Given this list of marker genes Ss18l1, Limd1, Parp6, Fyn (NCBI Gene Id 14360), Fn1, Myh14, Brwd1, Sema3e, Caprin2, Cul7, Cdc42se1, Cask, Palmd, Kit, Eef2k, Fblim1, Ccl11, Caprin1, Zranb1, Plxnb3, Vegfa, Slc30a1, Fbxw8, Rhou, Fmnl1, Arhgap15, Hdac6, Cux2, Stau2, Pakap, Sparc, Arhgdia, Mov10, Ccl24, Ankrd27, Gas7, Dapk3, Fermt2, Kif3a, Plxnb2, Cpne9, Xlr3b, Ezr, Smurf1, Reg1, Pak3, Bves (NCBI Gene Id 23828), Hck, Lpar1, Myo10, Nf2, Kalrn, Numb, Cdc42ep3, Enam, Rims1, Rhoj, Cdc42se2, Lst1, P2ry1, Rnf157, Fzd4, Septin7, Wtip, Ighm, Plekho1, Itga7, Cpne5, Syne3, Dvl2, Bcl9l, Mfn2, Ache, Mfn1, Syt4, Met, Myo9a, Crk, Zmym6, Rhobtb2, Strip1, Mfsd2a (NCBI Gene Id 76574), Tnik, Ptn, Coro1b, Coch (NCBI Gene Id 12810), Il6, Wdr1, Sema4d, Msn, Mecp2, Sh3glb1, Arhgef18, Ccl12 (NCBI Gene Id 20293), Arap1, Dlg1, Myl12b (NCBI Gene Id 98057), Fgr, Ptprd, Cdkl3, Fmnl3, Phip, Opa1, Ypel4 (NCBI Gene Id 241525), Dnm1l, Itpka, Fgd4, Fgd1, Cfap410, Macf1, Cldn4, Parvg, Shroom3, Map3k13, Camk2b, Syt17, Rreb1, Wnt5a, Reln, Cdc42ep4, Ccl7, Sprr2a1, Marcks, Cxcr4, Zmym4, Akap5, Arc, Epb41l2, Csf1r, Fbxo31, Prag1, Aldoa, Cyfip1, Atg16l1 (NCBI Gene Id 98282), Cacng7, Zmym3, Myh10 (myosin, heavy polypeptide 10, non-muscle), Kank1, Pten, Fitm2, Plxnd1, Pxn, Cpne6, Afdn, Syt1, Enpp2, Cldn3, Prkdc, Pias2, Dlc1, Tpm1, Gas2, Dmtn, Gna13, Lrp8, Ilk, Palm, Icam1, Coro1c, Obsl1, Plaa, Larp4, Picalm, Cfl1, Cd44, Src (NCBI Gene Id 99351), Kdr, Baiap2, Vil1, Arpin, S100a13, Cldn13, Epb41, Parva, Parvb, Myo5b, Cdkl5, Fmnl2, Tbc1d24, Mul1, Nherf1, Bcl11a, Sh3kbp1, Syt2, Cdc42ep2, Prkn, Fes, Grip1, Unc13a, Wls, Plxnb1, Sh3d19, Taok2, Prpf40a (pre-mRNA processing factor 40A), Coro1a (NCBI Gene Id 16902), Hpn, Epb42, Gna12, Efna5, Ostn, Ntng2, Rasal1 (NCBI Gene Id 19415), Epb41l3, Il1rapl1, Diaph1 (diaphanous related formin 1), Plxnc1, Capzb, Fam171a1, Ephb2, Dbn1, Sgk1, Hexb, Camsap1, Cfdp1, Ntng1, Actr2, Hnrnpk, Dvl1, Cdc42ep5, Epha4, Gm14137, Rac3, Dhx36, Eps8, Spag9, Bhlhb9, Wdpcp, Arhgap35, F2, Actr3, Arhgap18, Mkln1, Rhoq, Spta1, Rhobtb1, Dvl3, Myl12a, Dlg4, Pafah1b1, Wasf3, Bambi, Dnmbp, Tiam1, Ccl3, Rdx, Slc26a5, Cntn2, Dbnl, Mark2, Ermn, Slc23a2, Cdc42ep1, Sema4a, Brwd3, Ago4, Pdzd8, Mpl, Palm3, Rims2, Myh9, S100b, Syt3, Ptk2b, Anapc2, Ptprf, Rhog, Nedd4l, Ptk2, F11r, Zmpste24, Rac2, Tbccd1, Anxa1, Cux1, Sprr1b, Numbl, Anxa7, Rab21, Rac1, Itsn2, Pdpn, Strip2, here is a description of the gene set: species: Mus musculus Mouse Gene Set: GOBP_REGULATION_OF_CELL_MORPHOGENESIS Any process that modulates the frequency, rate or extent of cell morphogenesis. Cell morphogenesis is the developmental process in which the shape of a cell is generated and organized.